The following is a description of a gene set: studied in species Homo sapiens from publication Fu W, Ergun A, Lu T, Hill JA, Haxhinasto S, Fassett MS, Gazit R, Adoro S, Glimcher L, Chan S, Kastner P, Rossi D, Collins JJ, Mathis D, Benoist C (PMID 22961053) Genes down-regulated in CD4 T conv: control versus over-expression of XBP1 and FOXP3. The transcription factor FoxP3 partakes dominantly in the specification and function of FoxP3+ CD4+ T regulatory cells (Tregs), but is neither strictly necessary nor sufficient to determine the characteristic Treg transcriptional signature. Computational network inference and experimental testing assessed the contribution of several other transcription factors (TFs). Enforced expression of Helios or Xbp1 elicited specific signatures, but Eos, Irf4, Satb1, Lef1 and Gata1 elicited exactly the same outcome, synergizing with FoxP3 to activate most of the Treg signature, including key TFs, and enhancing FoxP3 occupancy at its genomic targets. Conversely, the Treg signature was robust to inactivation of any single cofactor. A redundant genetic switch thus locks-in the Treg phenotype, a model which accounts for several aspects of Treg physiology, differentiation and stability. Human Gene Set: GSE40274_CTRL_VS_FOXP3_AND_XBP1_TRANSDUCED_ACTIVATED_CD4_TCELL_DN, and this is the list of marker genes: BCL6, SEMA7A, PDE5A, FAM43A, ENG, CSPG4BP, TCEAL1, SRXN1, HDHD5, PGPEP1L, EPS8L1, POU2AF1, PNKD, ANKFN1, TNFSF4, SCAP, GRK3, SLC25A45, SUOX, ANPEP, MARVELD1, TMEM18, FERMT3, PENK, CYTIP, JAG1, CASTOR2, HDAC7, TMEM164, ITK, SLC29A3, STX3, BCL3, PPT2, SSBP2, RPS8 (ribosomal protein S8), GDPD1, SMURF1, CLEC4E, KLF2, B3GLCT, LITAF, DENND3, CAT, SHISA7, CSK, POLD4, RANBP10, DAPL1, CCR7, CAMP, ARHGAP45 (NCBI Gene Id 23526), MIR203A, IRF7, OTULINL, MMP9, HPCAL1, MTSS1, GAD2, BIN1, PTPRS, IFIT1, TAMALIN, TMEM121B, OSBPL3, FMO5, HS1BP3, RELL1, RAPGEFL1, SLC9A1, MXD4, NUDT16 (NCBI Gene Id 131870), ACTN1, FMNL3, TMEM86A, GNAT3, PEG10, MAN1C1, H2BC21, LGALS3BP, NECTIN1, NXPE4, FUZ, PFKFB4, PARVG, CD8B (NCBI Gene Id 926), MAG, SEMA4A, PDE6D, WIPI1, AMPD3, ACCS, STARD3, ABCA7, BCKDHA, NPC2, HSPB6, SYVN1 (synoviolin 1), ARHGAP39, S100A1, ZC3H12A, FAM114A1, CD302, CYLC1, UBXN11, ZMIZ2, NIBAN2, SPATA13, IL1A, SULF2, CLEC1B, RASSF4, TMCC3, LGMN, SCAMP1, RABAC1, GAB3, CALB2, CALCOCO1, FAM193B, LANCL1, CLEC2D, ITGB5, NCKIPSD, PRKAB1, P2RY6, RAPGEF4, PSEN2, HK3, SLC16A9, SUSD2, PECAM1, MSR1, PTK6, EHD3, KLHL14, PARP8, ITGA5, SBNO2, FRMD4A (FERM domain containing 4A), MXRA8, F2RL2, VOPP1, STOM, LMBR1L, CDS1, VIM, MAP4K3, MPP1, FIS1, YPEL5, CYB5A, TMEM219 (NCBI Gene Id 124446), LPAR6, ATOSA, BLCAP, RUNX3